The following is a description of a gene set: Human Gene Set: GOBP_NEGATIVE_REGULATION_OF_MEIOTIC_CELL_CYCLE_PHASE_TRANSITION studied in species Homo sapiens Any process that stops, prevents or reduces the frequency, rate or extent of meiotic cell cycle phase transition., and this is the list of marker genes: TTK, ZWINT, OVOL1, PKMYT1, PDIK1L, CHFR, KNL1, MOS, STK35